Given this list of marker genes METTL1 (NCBI Gene Id 4234), DEGS1, CRTC3, IL1RL1, CLEC12A, TMEM120B, CLUAP1, NDUFA10, MRTO4, TROAP, SHQ1, TMEM51, COX8A, ACOT7, DHX9 (NCBI Gene Id 3450), VILL, NOP10, KHK, TOB1, B3GALT2, BABAM2 (BRISC and BRCA1 A complex member 2), DCLRE1B (NCBI Gene Id 64858), EMILIN1, HNRNPH1, H1-10, BPNT1, RELT, CDC45, TM2D2, TTC3, CD151, PRIM1, HSP90AB1, DGCR2, PDAP1, NLRC3, NUMA1, TNFRSF13B, CHCHD3, PPP2R5D, RUVBL1, ABT1, KIF23, PGLYRP1, DDB1, MTFR1L, PPP5C, TMEM176A, NOL11, OPN3, CCDC14, PRKAG2, XRCC6, C8G, CLNS1A, GGA3, KLHL21, SNRNP70, SEPTIN6, TBCD, ACYP1, L3MBTL2, PITRM1, GSDME, MZT2B, NDE1, HNMT, GPR146, THAP11, PPP1R10, HAVCR2, NISCH, TFEB, CSF1R, GUK1, TTLL1, LRRC57, TRMT12, SNRK, LTB4R, DCAF12, LMNB1, CLPP, DDX18, ANKRD22, CSNK1E, CCDC163, LANCL1, PUS3, PKD1, ABHD14B, CYP27A1, PLPP2, NHP2, NUDT8, SEMA6B, UTP25, PRC1, HCFC1, RAB44, SNX4, TRMT10A, CDKN2AIPNL, LHPP, DNAJC25, ZMYND8, HMGB1, CENPN, DNAJC24 (NCBI Gene Id 120526), ARHGEF1, XBP1, VARS1, MCCC2, TMC8, PSTPIP1, ARRDC4, PSTK, IMPDH2, DTX3, NOL9, LYRM7, ADK, CDCA3, MYL12B (myosin light chain 12B), IL1R2, GTF2H5 (general transcription factor IIH subunit 5), POC1B, CDT1, ALG8, ZDHHC13, FECH, POLA1, TMEM53, RBM44, PDP1, NEK9, SMYD3, HAUS4, PPID, NRBP2, PAQR7, PHF5A, DCPS, MGMT, LIN7C, HAUS1, SNX15, MTHFD1, H1-5, GPATCH1, GNL3, MLH1, LSM4, MRPS27, ZBTB45, TKT, BHLHE40, ADPGK, NF2, PPP1R14B, PMS2, HDAC8, TYW1, PLOD1, CBX8, AGPAT4, WWOX, MTCH1 (mitochondrial carrier 1), ZMYND19, NT5C, RWDD2A, BOP1, RAD54L, CASP6, RAD51D, here is a description of the gene set: Genes up-regulated in macrophages with IL10 knockout treated by LPS and IL10: 10 min versus 30 min. IL-10 regulates anti-inflammatory signaling via the activation of STAT3, which in turn controls the induction of a gene expression program whose products execute inhibitory effects on pro-inflammatory mediator production. Here we show that IL-10 induces the expression of an ETS family transcriptional repressor, ETV3 and a helicase family co-repressor, SBNO2 (Strawberry notch homolog 2) in mouse and human macrophages. IL-10-mediated induction of ETV3 and SBNO2 expression was dependent upon both STAT3, and co-stimulus through the TLR pathway. We also observed that ETV3 expression was strongly induced by the STAT3 pathway induced by IL-10 but not STAT3 signaling activated by IL-6, which cannot activate the anti-inflammatory signaling pathway. ETV3 and SBNO2 specifically repressed NF-kB-mediated transcription and can physically interact. Collectively our data suggest that ETV3 and SBNO2 are components of the pathways that contribute to the downstream anti-inflammatory effects of IL-10. We compared expression profiles of macrophages isolated from IL-10 -/- mice. Macrophages were treated with either LPS or LPS plus IL-10. Treatment times were 10, 20 and 30 minutes. from publication El Kasmi KC, Smith AM, Williams L, Neale G, Panopoulos AD, Watowich SS, Häcker H, Foxwell BM, Murray PJ (PMID 18025162) studied in species Homo sapiens Human Gene Set: GSE9509_10MIN_VS_30MIN_LPS_AND_IL10_STIM_IL10_KO_MACROPHAGE_UP